The following is a description of a gene set: Genes having at least one occurence of the motif GACTGTT in their 3' untranslated region. The motif represents putative target (that is, seed match) of human mature miRNAs hsa-miR-212 and hsa-miR-132 (v7.1 miRBase). Human Gene Set: GACTGTT_MIR212_MIR132 studied in species Homo sapiens, and this is the list of marker genes: PPM1G, PPP2R5C, PCDH10, H3-5, EP300, PXN, PRICKLE2, PFN2, ILRUN, SOX4, NSD3, ARHGAP32, HNRNPU, TJAP1, LSM11, FKBP2, PHF12, DAG1, CBX1, ANP32A, TIMM9, DHX57, MAPK1, SOX11, AMD1, BRCA1, NOVA1, SEMA6A, SSH2, SEPHS1, EIF4A2, SRGAP3 (SLIT-ROBO Rho GTPase activating protein 3, NCBI Gene Id 9901), KCNA6, BRI3, KCNJ12, CNIH1, LRRFIP1, FAM76B, TUT4, TAF4, ATXN1, NFYA, LRRC55, DNAJB14, CELF2, DNAJA2, RFX3, H3-3B, OSBPL8, TMEFF1, FAM91A1, MAPKAP1, DYNLL2, SPPL3, WT1 (WT1 transcription factor), FUBP1, HMGXB4, FAM167A, MIDEAS, TCF7L1, USP9X, DPYSL3, ZFC3H1, PCGF3, CREB5, DESI2, OLFM1, NREP, KCNJ2, SLC30A6, PAIP2, PRP4K, PURB, PEA15, MEPCE, MMP16, SOX6, FOXA1, DEDD, ZNF644, ELFN2, DAZAP2, MYCBP2, BTBD7, RDX, ADCY3, AZIN1, ISL1, BOLL, JPT1, TRIM2, BTG2, PAPOLA, H2AZ1, CALU, HMGA2, USP9Y, TSC22D3, YWHAG, PHF20L1, PRRT2, DUSP9, CTDSPL2, SPRED1, SIRT1, NCALD (NCBI Gene Id 93992), GTDC1, MEX3B, ARHGEF11, ARID2, ADAMTS5, CRACDL, BRWD1, NEIL2, KCNK2, HNRNPM, PNN, AKIRIN1, BCAN, KLHDC10 (kelch domain containing 10), SLC6A1, TAF15, PSMD12, RGS7BP, PTBP2, SPTSSA, C19orf47, FXR1, LZTS3, CSDE1, SGK3, LIN28B, MEX3C, SEMA4G, ZEB2, C1QL1, CDK14, NMNAT2, RAB15, BNC2, SCN3A, SPRY1, RASA1, FOXO3, POM121, LARGE1, SAP30L, MECP2, SOX5, AFF4, PLXND1, CFL2, BNIP2, FEM1C, KMT5B, NPAS4, ZBTB18, NR4A2, MAF, NDRG4